Given this list of marker genes Setd2, Mettl23, Prmt9, Carm1, Setdb2, Wdr5, Suv39h1, Smyd1, Prmt6, Setmar, Fbl, Nsd2, Prdm13, Ndufaf7, Suv39h2, Kmt2d, Ash1l, Nsd3, Setd1a, Mettl22, Prmt1, Ezh1, Jarid2, Kmt2e, Mecom, Prdm16, Prmt3, Vcpkmt, Ehmt2, Smyd2, Prdm8 (NCBI Gene Id 77630), Setd3, Ehmt1, Kmt5c, Ezh2, Prmt7, Suz12, Prdm6, N6amt1, Ash2l, Kmt2c, Setdb1, Eef2kmt, Eef1akmt2, Kmt5a, Mettl21a, Antkmt, Kmt5b, Prmt5, Dot1l, Setd4, Eef1akmt3, Kmt2a, Fbll1, Setd5, Smyd5, Prmt8, Atpsckmt, Prdm9, Smyd3, Kmt2b, Eef1akmt1, Setbp1, Ntmt1, Prmt2, Setd7, Setd1b, Nsd1, here is a description of the gene set: Catalysis of the reaction: S-adenosyl-L-methionine + histone = S-adenosyl-L-homocysteine + methyl-histone. Histone methylation generally occurs on either an arginine or a lysine residue. studied in species Mus musculus Mouse Gene Set: GOMF_HISTONE_METHYLTRANSFERASE_ACTIVITY